The following is a description of a gene set: Any process that stops, prevents, or reduces the frequency, rate or extent of granulocyte differentiation. species: Mus musculus Mouse Gene Set: GOBP_NEGATIVE_REGULATION_OF_GRANULOCYTE_DIFFERENTIATION, and this is the list of marker genes: Rara, Ceacam1, Inpp5d, Cul4a, C1qc, Trib1, Zbtb46, Runx1, Adipoq, Prdm16